Given this list of marker genes CDV3, NEIL1, CHURC1, EMC10, KMT5A, NACC1, FKBP4, NINL, ZCCHC17, CDC42EP1, MIDN, KXD1, DUS3L, GADD45B, ARF6, TSLP, SMARCC1, COX19, NLN (NCBI Gene Id 57486), KCNG1 (NCBI Gene Id 9035), PAM16, RALA, PRC1, GSE1, SYCN, URB1, IL1RN, HJURP, NAP1L4, FRRS1, DGKZ, ABLIM2, FAM199X, CEP78, CSNK1G2, MAP3K11, HMGA1, N4BP3, SYNPO2L (NCBI Gene Id 79933), VASH2, EVA1A, MUL1, ZNF740, EEF1E1, STARD4, SS18L2, POLD3, XPOT, HNRNPC, SNRNP27, WWC1, HPF1, BAG6, PPP2R5E, PARD6G, RSL24D1, PPP2R3C, NRBF2, SLC39A7, AFG2B, NATD1, UBL4A, EVPL, RRAGA (Ras related GTP binding A), MRPS2, CASP14, SYT4, POC5, RAB25, GLRX2, LARGE2, AP4S1, ATF6B, ATAD2, CEP43, MRPS21, AIMP2, PYCR2, PGAP1, RAD51, MED19, ING2, UBE2R2, NIPAL1, DCAF13, FAM120C, AJUBA, LANCL1, MAPK1, PRADC1 (NCBI Gene Id 84279), TUBA8, TBC1D10A, HCFC1, PPARD, WDR75, TFRC, LSR, SLC25A46, ELOC, HOXB5, ZFTRAF1, MYMK, ARL6, ZNF598, BLOC1S3, SNX12, MMACHC (NCBI Gene Id 25974), SIPA1L1, GPR87, FBRS, GMEB1, NR2F6, JUNB (JunB proto-oncogene, AP-1 transcription factor subunit), MTHFSD (NCBI Gene Id 64779), PKP2 (NCBI Gene Id 93271), TMPRSS13, PTMS, SYTL1, USP46, GADD45A, ESRP2, TMEM131L, NCAM2, SAMD8, PRDM2, EXOC3, SND1, WASHC3, REX1BD, SNAP29, IST1, MEMO1, NUDT18, HCFC2, PLK2, COPS3, IGSF9, C3orf52, AHCYL2, SC5D, RHOD, RBM27, TMA7, DANCR, PYCR1, LRP10, RABL3 (RAB, member of RAS oncogene family like 3), HRAS, TMEM183A, C9orf72, BAIAP2, ANKRD54, ALG2, SEPHS2, TSPAN31, ZFPM1, PDCD5, RHBDF2, ZC3H18, ALYREF, TBP, PCNX3 (pecanex 3), FAM89A, EIF4ENIF1 (NCBI Gene Id 56478), BEND3, CKMT1B, DMPK, CBX2 (NCBI Gene Id 876), TSNAX, CHI3L1, PRELID3B, PRAMEF12, PCDH1, SENP2, TSPAN9, DNAJB2, EMC6, NDUFA3, ARIH1, TCF12, C18orf32, NAA38, LETM1, MGST3, MAIP1, TMEM54, PCBP4, CHGA (NCBI Gene Id 1113), EIF2D, CACNG6, NSF, MAP1LC3A, MACROH2A1, RAB3B, SNORD104, TUBGCP6, UXT, INAVA, IER2, IER5, here is a description of the gene set: We demonstrate that the G protein Gi3 is the cellular target of the adenosine A3 receptor (A3R). By using a cell permeable peptide comprising the C-terminal end of Gαi3 fused to an importation sequence (ALL1) as a selective inhibitor of Gi3 signaling, we show that by coupling to Gi3, the A3R stimulates multiple signaling pathways in human mast cells, leading to upregulation of cytokines, chemokines and growth factors.Following contact with activated T cell membranes, endogenous adenosine binds to and activates the A3R, resulting in Gi3-mediated signaling. Specifically, the majority of ERK1/2 signaling initiated by contact with activated T cell membranes, is mediated by Gi3, giving rise to ALL1-inhibitable cellular responses. These results unveil the physiological GPCR that couples to Gi3 and establish the important role played by this G-protein in inflammatory conditions that involve adenosine-activated mast cells. We used microarrays to detail the effect of ALL1 on gene expression of HMC-1 cells activated directly by the A3 receptor, or by contact with activated T cell membranes. from publication Baram D, Dekel O, Mekori YA, Sagi-Eisenberg R (PMID 20190146) species: Homo sapiens Human Gene Set: GSE19888_ADENOSINE_A3R_INH_VS_ACT_IN_MAST_CELL_UP Genes up-regulated in HMC-1 (mast leukemia) cells incubated with: the peptide ALL1 versus Cl-IB-MECA.